Given this list of marker genes Hsd17b4, Acot8, Decr2, Abcd1, Eci2, Ehhadh, Mlycd, Acot4, Acaa1b, Slc27a2, here is a description of the gene set: electronically inferred by orthology from the curated human pathway part of: Peroxisomal lipid metabolism This event has been computationally inferred from an event that has been demonstrated in another species.<p>The inference is based on the homology mapping from PANTHER. Briefly, reactions for which all involved PhysicalEntities (in input, output and catalyst) have a mapped orthologue/paralogue (for complexes at least 75% of components must have a mapping) are inferred to the other species. studied in species Mus musculus Reactome Pathway: Beta-oxidation of very long chain fatty acids